Given this list of marker genes Atf7ip, Uvssa, C8a (NCBI Gene Id 230558), Rev3l, Nphp3, Parp8, Bmper, Sephs1, Wac, Lipa, Nap1l5, Tmem161b, Lpar4, Scpep1, Zfp442, Tesk2, Pid1, Stil, Jarid2, Fgf14, Cdk1 (NCBI Gene Id 12534), Cobl, Utp18, Cbfa2t3, Foxa2, Zfp143 (zinc finger protein 143), Gng3, Katnbl1 (katanin p80 subunit B like 1), Pcdh7, Zfp324, Dync1i1, Zdhhc14, Onecut2, Galr1, Adamts4, Rfx4, Gpd2, Slamf1, Togaram1, Gtf2i, Dbn1, Fgd4, Trpc5, Gzmn, Atxn1, Xk, Tfap2a, Vamp5, Eme1, Arfip1, Sema6a, Sftpb, Bcl2, Hells, Bicd2, Tpbpa, Zfp280b, Dclk1, Mxi1, Lipi, Hs6st2, Mthfsd (methenyltetrahydrofolate synthetase domain containing), Lhx9, Klhl4, Sec62, Rims2, Xkrx (NCBI Gene Id 331524), Shisa9, Zfp937, Zfp263, Elk3, N4bp2l1, Nap1l1, Zfp59, Fip1l1, Yy2, Ube2a, Higd1a, Zfhx3, Ehbp1, Atf6, Cnga3, Fndc5, Fbxo3, Slc26a4, Sh3glb1, Faxc, Map3k20, Bicd1, Zfp532, Sgtb, Eif1ad8, Msantd4, C1qtnf2, Zgrf1, Elf1, Stx8, Zbtb44, Maea, Morc3 (microrchidia 3), Ddx52, Grhl1, Tshz1, Nav1, Zfp956, Negr1, Tbc1d10b, Srek1, Lingo3, Polr1b, Chic1, Arhgap6, Unc5c, Meikin, Cttnbp2nl, Qdpr, Tfcp2, Rapgef2, Cntln, Fam13a, here is a description of the gene set: studied in species Mus musculus Mouse Gene Set: MIR_876_5P from publication Chen Y, Wang X (PMID 31504780) Genes predicted to be targets of miRBase v22 microRNA mmu_miR_876_5p in miRDB v6.0 with MirTarget v4 prediction scores > 80 (high confidence targets).